Given this list of marker genes GRAMD1A, NANOS1, CHD5, OSR1, UBE3C, NTNG1 (netrin G1), ATG16L1, ZNF367, PRR15, ANKIB1, GNS, RUFY2, CNOT4, OCRL (NCBI Gene Id 4952), STXBP5, RAB22A, GPATCH2, TAOK3, NDEL1, ABHD5, AAK1, FBXO48, SLC40A1, NCKAP5 (NCBI Gene Id 401013), ZNF25, GXYLT1, CMTR2, DCBLD2, DNAJC16, TM2D2, NACC2, PLEKHA3, RRAGD, SMAD5, FGD5, LRIG1, REV3L, FAM13C, FAT2, ATXN1L, KIAA1191, PAPOLA, MYNN, ATXN7L1, BEST3, USP31, RAB30, SIKE1, DDHD1, NEDD4L, ZBTB21 (NCBI Gene Id 57487), GNPDA2, WDFY3, PCDHA3, TNFAIP1, DNAJC27, MIDN, PARD6B, ZBTB4, ZDHHC9, FNBP1L, CAPN15, CSRNP3 (cysteine and serine rich nuclear protein 3), RAP2C, SEMA7A, DUSP8, KLHL15, PPP1R3B, AKAP13, LRP8, BTN3A1, ZNF280B, REST, ABCA1, MCF2L, UBXN2A, ZNF148, PGM2L1, RSRP1, ZNF652, IGSF10, TMBIM6, PLAGL2, E2F1, ABI1, TMEM168, RGMB, BHLHE41, FRMD6 (FERM domain containing 6), RRAS2, MEX3D, UNC80, TBC1D9, TNFRSF21, ZBTB41, ERC1, ANKH, TBC1D8B, MTMR3, PLAG1, TMEM138, UXS1, ZNF704, TENM1, ZFYVE9, GPR137C, NR2C2, LIMK1, NCOA3, ITGA4 (NCBI Gene Id 3676), AKTIP, RASGRF2, SOS1, URI1, CHRM2, HIF1A, KLF11 (NCBI Gene Id 8462), ZBTB18, FSD1L, ARHGEF18, EIF4A2, VLDLR, ZNF800 (zinc finger protein 800), SLMAP, ANKRD17, SLC22A23, SNX16, KCNB1, PURB, PTPN4, DUSP2, FGD4, HAUS8, RBL1, THRA, MED12L, ADARB1, P2RX4, MKNK2, SH3BP5, PSG3, CXCL6, RORC, LPGAT1, SLC24A2, SMAD4, SLC49A4, ELK4, CYBRD1, MAPK1, HS3ST5, PCDH15, ARHGEF10, RAB8B, SLC16A6 (solute carrier family 16 member 6), ZNFX1, EMSY, RLIM, RPS6KA6, SLC16A9, PCDHA10, PAPOLB, C14orf28, MARCHF8, PTGDR, RNASEH2B, PITPNA, ANKRD52, CROT, SSX2IP, ANKRD50, PLXDC2, BTBD7, DDX5, SAR1B, PXK, DRD1, CMPK1, PEX5L, WDR37, HECTD2, SNTB2, CENPQ, LAMA3, NEUROG1, FAT4, GPR6, MFSD8, PLXNA1, IL1RAP, TPRG1L, MFAP3L, SALL3, ZBTB33, RNH1 (ribonuclease/angiogenin inhibitor 1), AHNAK, NAA30, AMER2, SERF1B, SACS, CHP2, ST3GAL1, CDC37L1, APP, CALD1, PAG1, GOLGA1, MYO5B, TRIP11, TMEM167A, HAS2, CDC23, BCL11B, FEM1C, TP73, ZNF597, ATAD2, LAPTM4A, RHOC, FBXO31, MKRN1, STAT3, RPS6KA4, NKIRAS1, CEP120 (centrosomal protein 120), SCN1A, MAP3K8, BCL2L11, GABBR2, HYCC2, FAM219B, ITGB8, EZH1, PCDHAC2, RUNX3, FCHO2, DYNC1LI2, ENTREP2, GPR137B, EREG, PCDHA8, PDE3B, CLOCK, RACGAP1, MAP7, KLHL2, LCOR, SCAMP5, USP46, ZFYVE26, KIF3B, TRIP10, BNIP2, ZBTB8A, KMT2A, BRMS1L, ARHGAP1, L3MBTL3, SSH2, LHX6, DOCK4, NFIC, SSH1, PAK5, LDLR, ZFPM2, UEVLD, KMT2B, EFCAB14, IRF1, LZIC, JPT1, UBE2Q2, WNK3 (WNK lysine deficient protein kinase 3), PBX3, PXYLP1, TRIM37, ZDHHC1, KCNJ10, CLIP4, NABP1, RBBP7, TNKS1BP1, SCAMP2, FRS2, PTPDC1, EPS15L1, ZNF202, WFS1, ARHGEF3, CTSA, ENPP5, LDLRAP1, LMO3, LIMA1 (LIM domain and actin binding 1), TGM2, CFL2, EIF5A2, EPHA7, REEP3, BICD2, ZNF264, ZNF827, KMT5B, FZD3, BNC2, TAOK1, MAP3K9, PKD2, PPP3R1, ADAM9, WEE1, MAGI3, ZFP91, AGFG1, RASD1, PCDHA12, LASP1, MAP10, ERAP1, GNB5, NRIP3, NHLRC3, ANKFY1, SLITRK3, OLFM3, PHIP, TNKS2, TBC1D20, KLF9, PPP1R15B, CERCAM, STYX, HPS5, AGFG2, ARHGAP12, FOXK2, PPP1R21, IRF9, ANKRD33B, KAT2B, STK11, ATG2B, FBXL5, ANKRD29, SYTL4, BAHD1, EPHA4, SLC33A1, RNF128, MFN2 (NCBI Gene Id 9927), KPNA2, SPRED1, AP2B1, PIK3R1, FNDC3B, C2CD2, FAM199X, NFAT5 (NCBI Gene Id 10725), SERTAD2, PRRG1, TRPV6, XRN1, NTN4, KIF23, DCUN1D1, IQSEC2, USP28, CREB1, LYPD6, IL6ST, NBEA, ULK1, ARHGAP26, STK38, MOSMO, CCNG2, FOXJ3, USP32, TGFBR2, NPLOC4, ZNF512B, SLC4A4, PCDHA6, RGMA, AGTPBP1 (ATP/GTP binding carboxypeptidase 1), ARID4B, NAPEPLD, KLHL28, MAP3K14 (mitogen-activated protein kinase kinase kinase 14), VASH2, DAB2, PCDHA13, GLIS3, CEP170, PCDHAC1, PFKFB3, TRAPPC14, ENTPD4, ATG14, GAB1, RETREG3, DENND5B, ANO6, U2SURP, PKD1, SH3PXD2A, RASL11B, MAPRE3, PSD, USP3, PCDHA1, TMEM127, RBL2, STRIP2, RAB11FIP5, VSX1, TGFB1I1, CAMTA1, ZBTB9, PANX2, ATP12A, CRYBG3, PPP6C, SUCO, ZBTB20, ARHGEF28, ZBTB7A, BBX, RCCD1, CORO2B, C9orf40, SESN3, APCDD1, RAB5B, TMEM265, SOX4, PCDHA5, CREB5, FBXL3, PRR14L, ANKRD13C, REPS2, CTSK, SPOPL, ARMC8, TOPORS, OSM, FBXO21, MAPK8, TMEM64, USP24, SRPK2, TRIM3, PHC3, FAM13A, RETREG2, EGLN3, ST6GALNAC6, BICC1, TRDN, SCN2B, EGR2, RBM12B, DERL2 (derlin 2), HLF, ABL2, ARID4A, PDCD1LG2, FJX1, SFMBT1, CNOT6, TMEM100, KIAA0513, BTBD10, PRR16, UNK, ITPRIPL2, TXNIP (thioredoxin interacting protein), TIAM1, PFKP, NIPA1, ZC3H12C, BTG3, NIBAN1, ZFAND4, PCDHA11, NR2C1, MAPK4 (mitogen-activated protein kinase 4), NPAS2 (neuronal PAS domain protein 2), HSPA8, PDLIM5, EPHA5, PRCP, TFAM, STK17B, RAPH1, BMPR2, OSTM1, TMX3, RAB11FIP1, DENND10, AGO1, LRRC55, ORMDL3, ABCG4, BRWD1, CNOT7, EEIG1, ZHX2, PTPRD, ZSCAN20, NPAT, OTUD4, DPYSL5, ROCK2, F3, RAB10, GPR63, GUCY1A1, DNAJB9, YOD1, SLC17A7, PCDHA2, S1PR1, SGTB, SMOC2, HEG1 (NCBI Gene Id 57493), ACSL4, RB1CC1, RORA, FLT1, SALL1, FAM117B, AFG1L, MAP3K2, UNKL, TAFA1, B3GALT2, MINK1, MMP24, ETV1, LYST, AKAP11, CCDC71L, TSPAN9, SEMA4B, NIN, RAPGEFL1, PCDHA4, PGBD5, CRY2, SRCIN1, ABHD2, CNRIP1, FAM210A, HTR2A, ATXN1, RPS6KA5, SERF1A, SAMD12, SNX8, DPYSL2, MTF1, E2F5, USP6, SQSTM1, SLC46A3, PTPN3, KATNAL1, PDGFRA, SGMS1, MYT1L, SMOC1 (NCBI Gene Id 64093), ATL3, CCND1, TET1, PCDHA7, HBP1, VANGL1, CD274, SLC4A8, KIF26B, RNF6, MCL1, ISM2, GOSR1, PTHLH, TANC1 (NCBI Gene Id 85461), TSG101, FYCO1, OXR1, CC2D1A, CNOT6L, NUP35, SEPTIN2, LRCH1, RGL1 (NCBI Gene Id 23179), CD69, SERP1, ZXDA, NAGK, CAPRIN2, CEP97, SLAIN2, ELK3, PTPN21, ZNF236, SRGAP1, SUSD6, TET3, PRDM6, RRM2, ARHGEF11, CMKLR1, NFIB, WDFY2, MYLIP, KCNK10, TRIM36, MASTL, C2orf69, TAGAP, DNAL1, LRPAP1, here is a description of the gene set: Genes predicted to be targets of miRBase v22 microRNA hsa-miR-17-5p in miRDB v6.0 with MirTarget v4 prediction scores > 80 (high confidence targets). from publication Chen Y, Wang X (PMID 31504780) species: Homo sapiens Human Gene Set: MIR17_5P